The following is a description of a gene set: Mouse Gene Set: GOMF_HEMOGLOBIN_ALPHA_BINDING studied in species Mus musculus Binding to a hemoglobin alpha chain., and this is the list of marker genes: Hbb-bs, Hbb-bh0, Hbb-bh1, Hbb-y, Hbb-bt, Hbb-bh2